The following is a description of a gene set: The chemical reactions and pathways involving a nucleotide, a nucleoside that is esterified with (ortho)phosphate or an oligophosphate at any hydroxyl group on the glycose moiety; may be mono-, di- or triphosphate; this definition includes cyclic nucleotides (nucleoside cyclic phosphates). Mouse Gene Set: GOBP_NUCLEOTIDE_METABOLIC_PROCESS species: Mus musculus, and this is the list of marker genes: Acp3, Mdh1, Art2a, Eno1b, Oasl2, Nme4, Pklr, Ak2, Hk2, Dctpp1, Ndufb7, Dlst, Mlx, Gtpbp1, Fmo2, Shpk, Stat3 (signal transducer and activator of transcription 3), Aldoc, Mfn1, Pde5a, Gapdhrt2, Pid1, Prps1l3, Hk3, Hspa1b, Adcy3, Cda, Acacb, Ppargc1a (NCBI Gene Id 320239), Pgam2, Myog, Taldo1, Zbtb7a, Psen1, Rhoa, Adsl, Pgd, Nudt15, Nudt3, Vcp, Ndufa8, Map2k1 (NCBI Gene Id 26395), Gmps, Antkmt, Pde4a, Gapdhs, Fignl1, Nudt5 (NCBI Gene Id 53893), Got2, Npr2, Zbtb20, Atp1b1, Selenon, Ido1, Ak6, Gucy2c, Tymp, Hdac4, G6pd2, Aldob, Ndufa5, Uprt, Guca1b, Ran, Uckl1, Nt5c, Uck1, Nppc, mt-Atp6, Nppa, Sdhd, Atpsckmt, Idh2, Ada, Atp5f1e (ATP synthase F1 subunit epsilon), Dut, Bcl2l1, Gpd1, Nmnat2, Ndufa3, mt-Atp8, Ampd2, Ampd1, Tkt, Ampd3, Entpd5, Idh1, Ndufc1, Slc25a12, Aldoa, Ncf1, Ndufa9, Papss1, Ppp2ca, Macroh2a1, Cnp, Slc4a1, Parp14 (NCBI Gene Id 72239), Sdhc, Slc25a51, Nudt4, Atp5f1c, Rrm1, Guca1a, Sult1c1, Dctd, Naprt, Impdh2-ps, Tigar, Pkm, Ldhb, Aldh1l1, Efl1, Stoml2 (NCBI Gene Id 66592), Slc25a13, Nudt18, Nadk2, Ndufv2, Tbpl1, Prxl2c, Gmpr2, Lipa, Adcy6, Parg, Hspa8, Cad, Atp7a, Aldh1l2 (aldehyde dehydrogenase 1 family, member L2), Ndufs6, Slc25a22, Prps1, mt-Nd2, Esrrb, mt-Nd6, Prkaa2, Lacc1, Fkrp, Ndufa10, Bloc1s6, Atp5pf, Nt5c3b, Naxe, Mapk1, Slc25a25, Atp5f1d (NCBI Gene Id 97661), Ins2, Guk1, Jmjd8, Pgk2, Pde8b, Tyms, Slc4a7, Gpd2, Uchl1, Paics, Pfkp, Pfkfb3, Actn3, Sult2a7, Atp5if1, Me2 (malic enzyme 2, NAD(+)-dependent, mitochondrial), Gmpr, Galk1, Khk, Rbks, Nme6, Nupr1, Pals1, Myh8, Ndufb4, Trex1, Dcxr, Ep300, Dnm1l, H6pd, Atp6v1b1, Dck, Sult2a3, Gpd1l, Sult2a6, Nt5c1a, Mthfd1, Pnp (purine-nucleoside phosphorylase), Noct, Gucy1b1, Gucy2e, Dmac2l (distal membrane arm assembly component 2 like), Col6a1, Prpsap1, Sarm1, Slc2a6, Slc52a2, Ncor1, Gucy1a1, Mdh1b, Adss2, Park7, Cmpk2, Ndufb11, Ndufs3, Nme2, Ndufa11, Atp6v1b2, Prps1l1, Cox11, Prkaa1, Upp2, Rhoq, Ppara, Gimap7, Rpe, Aco1, Sult1b1, Adpgk, Gapdh, Upb1, Samhd1, Nppb, Gpi1, Ak8, Nudt2, Rrm2, Slc4a4, Ndufb6, Nudt13, Foxk2, Pgam1, Nt5c1b (5'-nucleotidase, cytosolic IB), Xdh (NCBI Gene Id 22436), Fis1 (NCBI Gene Id 66437), Atp5f1b (NCBI Gene Id 11947), Adk, Dguok (NCBI Gene Id 27369), Ndufv3, Ndufs8, Dpyd, Eif6, Art2b, Il3, mt-Nd3, Htr2a, Trem2, Entpd1, Gnai3, Entpd7 (ectonucleoside triphosphate diphosphohydrolase 7), Pudp, Nt5c3, Atp5pd, Eno2, Ndufv1, Adcy2, Impdh2, Nudt11, Ifng, Sult2a4, Cacnb4, Kmo, Bend3, Eno3, Galt, Gars1, Ndufa13, Adcy7, Nt5c2, Enpp1, Shmt1, Pfkm, Rrm2b, Prpsap2, Ndufs4, Mlxipl, mt-Nd1, Ndufb5, Bpgm, Pals2, Upp1, Ak9, Mlst8, Urad, Nme1, Sirt6, Aspdh, Aldoart1, Papss2, Pcx, Myh3, Kars1, Tgfb1, Uqcc3, Mthfd2l, Slc25a11 (solute carrier family 25 (mitochondrial carrier oxoglutarate carrier), member 11), Nme3, Mfsd8, Nudt10, Hsd11b1, Tmsb4x, Fbp1, Ier3, Pde7b (phosphodiesterase 7B), Sdha, Rd3, Rptor, Tspo, Aldoart2, Slc25a18, Lrrk2, Atp5mg, Ak7, Myh7, Urah, Sult2b1, Dnajc30, Nudt9, Atp6-ps, Adcy8, Mdh2, Slc1a3, Pgls, Ido2, Ppat, Me1, Ak3, Ola1, Nme5, Prkn, Rora, Ndufa2, Ndufc2, Pgk1, Enpp3, Gck, Atp5mf, Aox1 (aldehyde oxidase 1), Fhit, Insr, Pth2, Slc52a3, Cbfa2t3, Foxk1, Shmt2, Ogt, Pde9a, Sphk2, Gucy2g (guanylate cyclase 2g), Nmrk2, Aprt (NCBI Gene Id 97468), Abcc6, Ndufb1, Ldhd, Gda, Mtch2, Tkfc, Atp2b2, Nudt16, Ndufs7, Ak4, Dhfr, Pde8a, Pde2a, Rnaseh2b, Tk2, Oga, Adora2b, Adcy9, Atp1a2 (NCBI Gene Id 98660), Impdh1, Cmpk1, Nt5m, Myh6 (myosin, heavy polypeptide 6, cardiac muscle, alpha), Hrh3, Igf1, Nt5e, Pfkl, mt-Nd4l, Npr1, Abcc9, Pde7a, Entpd4b, Ucp2, Dtymk, Atp5mc1, Eno4, Qprt, Arl2, Nudt17, Hnf1a, Ndufb10 (NADH:ubiquinone oxidoreductase subunit B10), Mtor, Gapdhrt, Adcy5, Sult1e1, Tpi1, Umps, Epha2, Sdhb, Dnph1, Ak1, Ndufb3, Slc29a1, Adcy4, Ndufb2, Nnmt, Gucy2d, Atp5f1a, Git1, Gart, Ndufs1, Nmnat3, Nudt12, Ndufa7, Haao, Nmrk1, Adcy10, mt-Nd5, Atp6v1a, Dpys, mt-Nd4, Ndufs5, Ctps1, Fam3a, Ndufa6, Ldhc, Ctns, Sult2a5, Pde4c, Itpa, Atg5lrt, Sult2a8, Ndufs2, Mpi, Ndufab1, Prps2, Gucy2f, Parp1, Pde1a, Atp5pb, Kynu, Cyb5r4, Ins1, Uck2, Uox, Ddit4, Ogdh, Sult2a1, Pnp2, Opa1, Nnt, Adcy1, Gale, Sik2, Prkag3, Ncf2, Pfas, Rpia, Letmd1, Pde4d, P2rx7, Cfh, Bcl2l13, Flcn, Atp5mc3, Pde10a, Naxd, Atp5po, Ak5, Ldha, Arnt, Ndufa12, Prkag2, Hif1a, Rab23, Trim63, Nadsyn1, Dhtkd1, Nampt, Il4, Oas1a, Dera, Nmnat1, Atp5mc2, Src, Trp53, Nos3, Eno1, Ndufb9, Adal, Ndufb8, Hkdc1, Dhodh, Myc, Slc37a2, G6pdx, Ndufa1, Hint1, Kat2b, Hprt1, Got1, Pfkfb2, Ctps2, Prkag1, Nme7, Sult2a2, Pfkfb1, Entpd4, Atic, Afmid, Flad1, Bad, Adss1, Nadk, Enpp5, Atp5me, App, Prkaca, Hk1, Rfk (riboflavin kinase), Clpx